Given this list of marker genes CIT, EVI2A, ZBTB7C, RGPD6, EYA2, DNMT3A, ANO1, CD5L, BTN2A2, PDE3B, RNGTT, NRG3, ELAVL4, RIMS2, ZNF616, AGAP1, DCP1A, OTULIN, BCLAF1, HS3ST3A1, ZNF559, VPS37A, DTNA, TRAM2, CHRNA1, GCC2, ADGRL3, EPPIN-WFDC6, P2RY12 (purinergic receptor P2Y12), PPP3R2, PMAIP1, PPFIA4, C5orf63, MACROD2, SLC2A14, NALF1, CHD8, PTPN3, RGPD8, AGO3, PLXNA2, CARNS1, ZCCHC2, AGO1, TBC1D16, DCAF5, LYN, RGPD5, UBN2, PCNX1, PPT1, MANEA, KDM7A, CRCP, GXYLT1, IQSEC1, SLC24A4, RGS4, CFAP91, PLD5, PDE1A, MAPK1IP1L, ASCL4, ADM, ZSCAN31, GRIA3, GLIS2, LDB2, RGPD4, RNF144B, CALU, SCIN, ARL5A, NOS1AP, LPXN, GMEB2, EHBP1, CLDN18, LRP11, MIER1, RAB29, RNF8, ADAM22, FGF18, MED13, CACNA1E, RPF1, TMEM50B, PRRX1, SUSD6, KLF6, NAA15, NTRK2, CCNT1, PPFIA2, SSBP3, UBE3D, EPHA8, ZNF502 (NCBI Gene Id 91392), ZFYVE27 (NCBI Gene Id 118813), RXRA, TNFSF4, TOR1AIP2, DYNC1I1, PLA2R1, LRP6, ARHGAP26, PLOD2, RNPC3, LARP1, SPATA31J1, CYRIA, ING5, EIF4EBP1, ZNF674, HMGXB4, MAP1A, IGFBP5, SYS1, CCT5, TARS3, UQCRFS1, TMTC2, here is a description of the gene set: Human Gene Set: MIR7111_3P Genes predicted to be targets of miRBase v22 microRNA hsa-miR-7111-3p in miRDB v6.0 with MirTarget v4 prediction scores > 80 (high confidence targets). species: Homo sapiens from publication Chen Y, Wang X (PMID 31504780)